The following is a description of a gene set: studied in species Mus musculus Genes positively differentially expressed in cell type: cDC1 (conventional dendritic cell type 1) upon treatment with cytokine: IL-2 in mouse lymph nodes in vivo. Cytokines mediate cell-cell communication in the immune system and represent important therapeutic targets. A myriad of studies have highlighted their central role in immune function, yet we lack a global view of the cellular responses of each immune cell type to each cytokine. To address this gap, the authors created the Immune Dictionary, a compendium of single-cell transcriptomic profiles of more than 17 immune cell types in response to each of 86 cytokines (>1,400 cytokine-cell type combinations) in mouse lymph nodes in vivo. A cytokine-centric view of the dictionary revealed that most cytokines induce highly cell-type-specific responses. For example, the inflammatory cytokine interleukin-1β induces distinct gene programmes in almost every cell type. A cell-type-centric view of the dictionary identified more than 66 cytokine-driven cellular polarization states across immune cell types, including previously uncharacterized states such as an interleukin-18-induced polyfunctional natural killer cell state. Mouse Gene Set: CUI_CDC1_IL2_RESPONSE_UP from publication Cui A, Huang T, Li S, Ma A, Pérez JL, Sander C, Keskin DB, Wu CJ, Fraenkel E, Hacohen N (PMID 38057668), and this is the list of marker genes: Cd274, Lap3, Rbbp8, Ffar2, G3bp1, Actr3, Mtdh, Pml (promyelocytic leukemia), Sp110, Mthfs, Marcksl1, Serpinb9, Srsf7, Tapbp, Pfkp, Fnbp1l (formin binding protein 1-like), Tspo, Ece1, Ccdc86, Syngr2, Pkib, Serpina3f, Dnajc2, Tpm3, Zbp1, Klrk1, Cdc14a, Srgn, Rnf213, Slc33a1, Cd38, Ptprc, Eif6, Kmo, Pnp, Pim1 (proviral integration site 1), Sdc4, Tapbpl, Eif2ak2, Lcp2, Casp4, Slc30a4, Cyba, Bax, Snu13, Coro2a, Bcl2a1a, Armcx6, Txndc17, Manf, Cmtm6, Spi1, Ikzf2, Ccnd2, Vasp, H2-DMb1, Pfn1, Nampt, Trio, Sdc3, Gpr33, Cdc42se1, Atp8a1, Nfkbie, Tuba1b, Procr, Larp1, Dock10, Gnb4, Isg15, Bcl2a1d, Parp14, Gbp2, Itgae, Syncrip, Ncbp3, Tmbim6, Ly6a, Htt (huntingtin), Sting1, Irgm2, Clic4, Psmb9, Mbd2, Hhex, Hnrnpd, Il10ra, Kif5b, Mvp, Rars1, Tmem131, Stat3, Gatm, Stx11, Cycs, Bcl3, Sh3glb1, Naaa, Bzw1, Ifi211, Lyn, Hspa5, Csf2rb2, Ncl, Eif5a, Fcgr4, Irgm1, Psma7, Napsa, Cflar, Ifi207, Pmepa1, Ube2l6, Hspa4, Gls, M6pr, Dnaja2, Serpina3g, Plek, Ccnd1, Prkcd, Cd300a, Psme2, Slfn5, Slfn2, Ube2d3, Irf5, Slamf8, Ifi47, Gbp4, Cdkn1a, Clec2d, Cxcl9, Nfkb1, Marchf5, Hsp90aa1, Tap2, Bcl2a1b, Apol7c, Fchsd2, Gyg1, Cd40, Zyx, Denr, Tma16, Icam1, Irf1, Psmb10, Myd88, Gbp5, Rnf19b, Litaf, Noc4l, Nlrc5, Etv6, Parp9, Srsf3, Stat2, Iigp1, Ccl12, Stat1, Cst3, Tpm4, Nedd4, Igtp (NCBI Gene Id 16145), Picalm, Ifi204, Basp1, Fam241a, Irf7, Ptpn1, Tor1aip1, B2m, Cxcl10, Psma2, Slc4a8, Chd1, Marcks, Ly6e, Dnase1l3, Eif1, Chd7, Nras, Tle3, Txn1 (NCBI Gene Id 22166), Efhd2, Cyrib, Ranbp1, Ms4a6c, Irf8, Calhm6, Ehd1, Ppa1 (pyrophosphatase (inorganic) 1), Hnrnph2, Morf4l1, Nfkbia, Eef1e1, Tln1, Trim30a, Pgam1, Ifi205, Mkrn1, Calr, Lcp1, Il4ra, Socs1, Nabp1, Pdia3, Ifi35, Samhd1, Mat2a